Given this list of marker genes Dld, Dhtkd1, Dlst, here is a description of the gene set: This event has been computationally inferred from an event that has been demonstrated in another species.<p>The inference is based on the homology mapping from PANTHER. Briefly, reactions for which all involved PhysicalEntities (in input, output and catalyst) have a mapped orthologue/paralogue (for complexes at least 75% of components must have a mapping) are inferred to the other species. electronically inferred by orthology from the curated human pathway species: Mus musculus part of: Lysine catabolism Reactome Pathway: OADH complex synthesizes glutaryl-CoA from 2-OA